The following is a description of a gene set: Human Gene Set: GSE29618_PRE_VS_DAY7_POST_LAIV_FLU_VACCINE_PDC_DN studied in species Homo sapiens from publication Nakaya HI, Wrammert J, Lee EK, Racioppi L, Marie-Kunze S, Haining WN, Means AR, Kasturi SP, Khan N, Li GM, McCausland M, Kanchan V, Kokko KE, Li S, Elbein R, Mehta AK, Aderem A, Subbarao K, Ahmed R, Pulendran B (PMID 21743478) Genes down-regulated in comparison of plasmacytoid dendritic cells (pDC) from influenza vaccinee pre-vaccination versus those at day 7 post-vaccination. Systems vaccinology has emerged as an interdisciplinary field that combines systems wide measurements and network and predictive modeling applied to vaccinology. Here we used the systems vaccinology approach to study the molecular mechanisms underlying th, and this is the list of marker genes: NSD1, EIF3M, OTUD4, RNF8, DNAJC13, PAXIP1, SENP3, PPP2CB, EIF5, ADAM10, INTS3, RTCB, RGS7, CIZ1, PSPC1, CDC16, ROGDI, SLC38A1, LSM12, CEP55, TUBB4B, ITGA4, IFRD1, WDR37, KPNA1, SNRNP200, NFYC, SYK, RBMS1, CCDC15, RIC8A, PMVK, JPT2, TUBB3, LHFPL2, MRPS16, LTN1, ZC3H14, PDXDC1, ARHGAP24, RNF130, KLF6, ZMYND8, MPRIP, ARCN1, UBR7, AZI2, SRSF6, CAPZB, CNTRL, UBE2B, SENP6, ARPC2, SAP30BP, DESI1, MALT1, SNAP23, FKRP, FASTKD2, PBX3, MAP3K14, ARHGAP12, PHKB, AP2B1, GDE1, MAT2A, MRPL3 (mitochondrial ribosomal protein L3), PTPRN2, PSMA7, BUD31, MMRN1, SCN9A, GIN1 (gypsy retrotransposon integrase 1), VSNL1, SLC25A3, KMO, PTEN, ACTA2, WASHC4, MICALL1, API5, APAF1, LIN37, FLOT1, DECR1, LIMK2, SIK1, NUP160, ELK3, CEP350, ANKMY2, TAF12, CEP290, RBM41, AIP, DXO, SERINC3, ABHD18, DMXL1, JAK2, LAMC1, NMD3, ALG5, IRF8, NCAPG2, ACAT1, PPP3CB, EIF2S2, CAPZA1, GTF2H5, EXOC5, MAP4K4, DUSP5, POLR2H, PAFAH2, IL4R, SLC39A7, VOPP1, CCNL1, ALCAM, ZNF592, ITGAV, WWOX, SLC33A1, GPR183, COG2, YPEL5, LARS1, ADAM22, OS9, EIF4A2, ZBTB33, RAB3GAP2, ELF1, NOP56, KYAT3, PRELID3B (PRELI domain containing 3B), MYEF2, OXCT1, ZNF135, MAP3K7, CDC7, SP4, SAGE1, TM2D1, ACSF2, CUEDC1, HSD17B4, ABCA6, UBE2K, ORC3 (origin recognition complex subunit 3), LRRC8D, ZNF226, EIF2B1, TANK, GNAS, TSPAN13, ENOX2 (NCBI Gene Id 95974), EPHB1, FIRRM, PRKCD, HARS1, SETD6, MRGBP, TMT1A, CENPU, RRN3, CES1, ATP6V1A, OPN3, DERL2, SH3BGR, PAFAH1B1, HUS1, SCN3A, RPL26L1, ZMYM6, RCN2, NDST2, MCM3AP-AS1, TBL2, RSRP1, TMEM185B, RIOX2, RPL23AP7, RMC1, SIDT1, HSPH1, SSB, TUBGCP4, TBCCD1, RBM8A, BTAF1 (B-TFIID TATA-box binding protein associated factor 1), ADAM19, RBM28, TIMM17A, ARMCX3, SRRD